Given this list of marker genes RDH5, MTFR1L, MME, RTL8B (NCBI Gene Id 441518), CSF3, SOX2, SAR1B, HOMER2, STAC, SFN, ABCA2, MYL11, POLR2H, ENY2, CCNE1, MAT2A (methionine adenosyltransferase 2A), MATN1, TRPC6 (transient receptor potential cation channel subfamily C member 6), UNC45A, TARS2, SERPINA10, MBD3, NOTCH4, COLQ, TSKU, EIF3D, REX1BD, TCEA2, NRBP1, SLC1A2, EIF3C, SSTR3, LYVE1, PPP1R2P1, GSTO1 (glutathione S-transferase omega 1), HTT, PTCH2, WNK2, TBR1, EMID1, SLC2A4, PHC2, DDX49, HES2, NAA10, PRKCSH, FOXD1, PVALB (NCBI Gene Id 5816), NR4A1, EFL1, CPT2, TSR1, HOXA3, EIF3A, PAK2, H2BC5, KIF9, MAPK3, SUMO2P7, SLC22A2, PTBP2, KLHL21, EMP2, APBB1, EEF1A2, HCLS1, DBP (NCBI Gene Id 1628), KLF10, PLXNA3, ERH, RBM38, ROCK1, SLC5A11, TFF1, WNT10A, GREM1, ALDH7A1, ARIH2, NTN1, CACNA2D3, C1GALT1C1, APOF, MRPL2 (mitochondrial ribosomal protein L2), MTMR14, AARS1, HIC1, LRRC59, SEMA6B, SPIB, NAMPT, BABAM2, DLX3, DCPS, C1QTNF1, CHPF, TMPRSS15, CACNG1, CCL4, RAD51D, MGAT3, PDCD1, LARP1, TBL3, AKR1C4, NKX2-2, AP2A1, ADISSP, GNL3, LRWD1, TOMM40, DOHH, RBP4, ARL10, NR2C2AP, URM1, HES3, NTSR1, MSH6, USF2, SCN3A, PRRC1, MRPL37, ITLN1, WDR5, EMC6, SAR1A, RPLP0, EFNA3, HIF3A, STAB1, B3GALT6, NSD1, PLXNA1, MXD3, SLC22A17, ELAC2, TGIF2 (NCBI Gene Id 60436), FOXD2, HTR2C, ARAP3, RAN, GPD1, PLAUR, IRS2, TULP1, RASGRF1, PFDN6, SEBOX, PPA1, SYNPO, PPP2R2B, SYT3, PCDH12, TOMM34, ADRA1A, CHMP7, RPS5, SLA, IFRD2, NFKBIB, PRKG2, NFS1, ANKRD1, MGP, SYCN, PICK1, TFIP11, DYM, STK19, HAX1, WDR43, RETSAT, HAUS5, GALNT10, PES1, LSR, ST6GALNAC4, RPL36, VEGFA, COL18A1, U2AF1L4, USP10, ELANE (NCBI Gene Id 6417), CREB1, MAT1A, PDLIM1, PHLDA2, MPL, EIF3L, WNT5B (NCBI Gene Id 84728), RRP9, PHF5A, ATG2A, SLC20A1, CLK4, TP63, EXOSC10, BCL7C, CCR9, RAD51B, here is a description of the gene set: Genes up-regulated in MME+ germinal center B lymphocytes: control versus over-expressing viral (EBV) gene LMP2A. from publication Vockerodt M, Wei W, Nagy E, Prouzova Z, Schrader A, Kube D, Rowe M, Woodman CB, Murray PG (PMID 23592216) Human Gene Set: GSE46143_CTRL_VS_LMP2A_TRANSDUCED_CD10_POS_GC_BCELL_UP In this study, we have investigated the effect of LMP2A on gene expression in normal human GC B cells using a non-viral vector based system species: Homo sapiens